The following is a description of a gene set: from publication Chen Y, Wang X (PMID 31504780) Mouse Gene Set: MIR_222_5P Genes predicted to be targets of miRBase v22 microRNA mmu_miR_222_5p in miRDB v6.0 with MirTarget v4 prediction scores > 80 (high confidence targets). species: Mus musculus, and this is the list of marker genes: Slc7a1, Med13, Nufip2, Cdh12, Akap9, Pabir1, Gucy1a2, Fgf10, Pex7, Pawr, Pak4, Nup153, Ppp2r2a, Zc2hc1a (NCBI Gene Id 99818), Atad1, Kansl1l, Mtmr10, Cd151, Ptpn3 (protein tyrosine phosphatase, non-receptor type 3), Tra2b (transformer 2 beta), Atosa, Loxl3, Lin28b, Nacc2, Fam110d, Slc39a10, Cnr1, Hs3st5, Patl1, Ube2w, Bcar3, Pnrc1, Vmn2r42, Taok1 (NCBI Gene Id 67240), Kdm6a, Ctsj, Slc7a13, Fam174a, Pde4b, Ak4, Nlk, G3bp2, Rfx3, Gna12, Piga, Chsy3, Adamtsl3, Vmn2r43, Cdh7 (cadherin 7, type 2), Prkx, Rb1, Vmn2r37 (NCBI Gene Id 22305), Dctn4, Sema3a, Sinhcaf, Phyhipl, Tlr4, Mug1, Dcx, Lbp, Trpc5, Golim4, Nutf2, Wnk1, Ube2j1, Rap2a, Pnisr, Cnih2, Adamts3, Hira, Mtf2, Plpp3, Capn6, Trim2, Traf3ip1, Acvrl1, Patz1, Dscam, Ankrd17, D030056L22Rik, Scd4, Celsr2, Serpine2, Ptpn9, Zfp217 (NCBI Gene Id 99438), Sh3glb1, Itga3, Cd2ap, Zbtb43, Tppp, Ncoa1, Col12a1, Tmem62, Gpr171, Zfp937, Thoc2, Ophn1, Ankrd44, Ppp2r5e, Psmd11, Fuca2, Ahnak, Abhd5, Pbk, P2ry10, Nectin2, Galnt7